The following is a description of a gene set: Mouse Gene Set: GOCC_APICAL_DENDRITE A dendrite that emerges near the apical pole of a neuron. In bipolar neurons, apical dendrites are located on the opposite side of the soma from the axon. studied in species Mus musculus, and this is the list of marker genes: Ptk2b, Slc4a10, Ykt6, Enpp1, Nefh, Cpeb3, Ptpn6, Myo1d, Rasgrf1, Slc7a10, Flna, Map1b, Ppargc1a, Hcn1, Elavl4, Whrn, Nsmf, Fas, Arpc2, Rgs12, Osbp2, Kif5a, Cask, Map2, Sez6, Slc1a1, Itsn1, Neurl1a, Slc17a8, Grin2b, Clu